The following is a description of a gene set: Human Gene Set: GSE27670_CTRL_VS_LMP1_TRANSDUCED_GC_BCELL_UP In this study, we have investigated the effect of BLIMP1α on gene expression, cell differentiation and pathogenesis in normal human GC B cells using a non-viral vector based system species: Homo sapiens Genes up-regulated in germinal center B lymphocytes: control versus over-expressing Epstein-Barr virus protein LMP1. from publication Vrzalikova K, Vockerodt M, Leonard S, Bell A, Wei W, Schrader A, Wright KL, Kube D, Rowe M, Woodman CB, Murray PG (PMID 21411757), and this is the list of marker genes: TOR1AIP2, ADAM23, KCTD10, RBM14, NEK6, SMARCD1, CMTR1, CDC25C, PSME1, IRF4, TM4SF5, BIRC2, BCL2A1, SEMA4A, OLR1, RAD54L, HLA-DMB, FGFR3 (fibroblast growth factor receptor 3), CCR2, MX2, TIMELESS, NFKBIB, TXNDC17, PTGS2, PDIA5, CD9, SMYD1, TSPAN33, SLC2A4, LSR, SWI5, HGD, COX8A (NCBI Gene Id 1351), PNKD, TNF, AP1G2, BEX1, SPR, MTHFD2, CASP4, HLA-DRB1, SLC2A2 (solute carrier family 2 member 2), PLEKHO1, PRKD3, RPP30, BMP2K, RBM8A, TPST1, CREB1, PPP2R1A, TNFRSF11B, MMP12, HSPA8, TBPL1, WNT11, BTF3, CIAPIN1, SMAD7, PBX1, ARPC5, APOF, PADI1, HNRNPH2, SLC22A5, STX2, ANPEP, KDR, CRYBG1, SEPSECS, SEC11C, CTBP2, TMEM50B, PPIH, GPR132, PCDHA10, ADAM8, KCTD20, H2BC18, PRIM2, FH, NEDD4L, NMI, TNFRSF4, ADAM19, GLOD4, CSTF3, ATP5MC2, TOX4, SULT4A1, NSA2, ESYT1, SELENOW, MRPS24 (mitochondrial ribosomal protein S24), FLG, CDKN2B, MYBL2, BRCA1 (NCBI Gene Id 672), NDRG4, SEM1, PRR5, HES5, SEMA5B, BATF3, UBAC2, GNRHR, CLDN1, SUB1, CHRND, SPP1, AURKB, IRF8, CDK1, AP1G1, IRF5, RPL30, IL4I1, POLB, GYS1, CFAP184, WARS1, DRG1, IMPA2, TWF2, RBBP7, S100A4, SEMA7A, RAD51D, ALPL, PTMS, FOXD4L1, PYGO2, PLK2, PNLIPRP1, GPD2, LIPC, BTG2, RPL10, SMTN, FCRLA, HOXA7, DNAJC5, RPA2, F11R, KLRD1, ATP5MK, DNAJC2, ZNFX1, SNORC, ENO3 (enolase 3), PML, RTN1, DDX27, TRIP13, RYR1, LIMD1, SELPLG, NFKB2, XCR1, EMP3, PARP8, TOP2A, ERO1B, NAPSA, GNB4 (G protein subunit beta 4), GCLC, PLEKHA5, CCND1, RPL39, NUP62, CIAO2B, APOH, ASF1B, MXD1, ARFGAP3, APIP, ASAP1 (ArfGAP with SH3 domain, ankyrin repeat and PH domain 1), SARNP, ZIC1, PSMA6, SRSF7, OLFM1, ERRFI1, FKBP1B, ISLR, CDKN1A, MRPL39, HINT1, MYCL, DUSP9, CDK14 (cyclin dependent kinase 14), HLA-DMA, IL15RA, ZNF277, HCN3, CACNB3, GRIN2C, PTGDR, CKS2, GFPT2, USP18